Given this list of marker genes Hadha, Gm6993, Sptssb, Sptlc1, Gcat, Acsm4, Scp2, Acsm1, Acat3, Acsm2, Acaa2, Sptlc3, Acsm5, Acaa1b, Sptlc2, Acat2, Sptssa, Slc27a3, Acsm3, Hadhb, Acat1, Acaa1a, here is a description of the gene set: Mouse Gene Set: GOMF_C_ACYLTRANSFERASE_ACTIVITY Catalysis of the transfer of an acyl group to a carbon atom on the acceptor molecule. studied in species Mus musculus